The following is a description of a gene set: species: Mus musculus from publication Chen Y, Wang X (PMID 31504780) Mouse Gene Set: MIR_668_3P Genes predicted to be targets of miRBase v22 microRNA mmu_miR_668_3p in miRDB v6.0 with MirTarget v4 prediction scores > 80 (high confidence targets)., and this is the list of marker genes: Mmgt1 (membrane magnesium transporter 1), Slc10a2, Zfp971, Abo, Dpp8, Cdh4, Otub2, Sanbr, Nfat5, Fat3, Usp37, Mospd1, Ms4a15, Xpo7, Epha4, Prc1, Lmod3, Ripk4, Hspa5, Nr6a1, Zfp1009, Bdh2, Sgsh, Tafa3, Csmd1, Zfp160, Nfib, Ppp3r2, Tm2d2 (TM2 domain containing 2), Ube4b, Glcci1, Ppp1r12c, Pcdh9 (protocadherin 9), Ercc2, Slc16a6, Kdm1b, Epb41l5, Oat, Dclk1, Rbbp9, Tsga10, Btg1, Nhej1, Hnf1b, Tmem138, Myh10, Nus1, Cdh5, Zxdb, Id4, Cfap141, Cldnd1, Lep, Pid1, Casp14, Mmp2, Ankib1, Marchf6, Vps41 (VPS41 HOPS complex subunit), Sele, Slc39a8, Ubr1, Cstf2, Foxa2, Prdm1